Given this list of marker genes CCNL1, PPP1R15A, SOD2, HSPH1, HSPA1A, GEM, HSPA1B, BAG3, SAT1, NAMPT (NCBI Gene Id 10135), C11orf96, SOCS3, CXCL2, NFKBIA, DUSP1, HES1, MYC, KDM6B, BRD2, TNFAIP3, MCL1, DNAJB1, KLF4, CCL2 (C-C motif chemokine ligand 2), NR4A1, IL6, GADD45B, FOSB, ID2, ADAMTS1, JUN, ATF3, BTG2, JUNB (NCBI Gene Id 90482), FOS, SERTAD1, CCN1, ID1, IRF1, IER3, CSRNP1, ICAM1, IER2, EGR1, NR4A2, NFKBIZ, MAFF, DNAJA1, ZFP36, CDKN1A, here is a description of the gene set: from publication Gavish A, Tyler M, Greenwald AC, Hoefflin R, Simkin D, Tschernichovsky R, Galili Darnell N, Somech E, Barbolin C, Antman T, Kovarsky D, Barrett T, Gonzalez Castro LN, Halder D, Chanoch-Myers R, Laffy J, Mints M, Wider A, Tal R, Spitzer A, Hara T, Raitses-Gurevich M, Stossel C, Golan T, Tirosh A, Suvà ML, Puram SV, Tirosh I (PMID 37258682) In this study, an extensive analysis was conducted to define meta-programs (MPs) capturing intra-tumor heterogeneity across a spectrum of tumor types. The approach utilized non-negative matrix factorization (NMF) to analyze each cell type separately within individual tumor samples. This involved the analysis of malignant cells, macrophages, fibroblasts, endothelial cells, epithelial cells, T-cells, and B-cells. NMF was executed with varying parameter values (K=4, 5, 6, 7, 8, 9), thereby generating 39 programs for each cell type per sample. Each NMF program was summarized by the top genes based on NMF coefficients.\nRobust MPs were then delineated for each cell type using a set of stringent criteria, including recurrence within the same tumor, similarity to programs in other tumors, and non-redundancy within a tumor. Subsequently, these robust NMF programs were clustered (per cell type) based on Jaccard similarity, leading to the identification of MPs associated with each cell type.\nTo enhance the quality of the MPs, a refinement steps were undertaken, involving the removal of MPs suspected of reflecting low-quality data (with an overrepresentation of ribosomal proteins or mitochondrial-encoded genes), single-study inclusion, or similarity to miss-annotated cell types. Human Gene Set: GAVISH_3CA_METAPROGRAM_FIBROBLASTS_STRESS Genes upregulated in subsets of cells of a given type within various tumors species: Homo sapiens